The following is a description of a gene set: Orthostatic hypotension due to autonomic dysfunction studied in species Homo sapiens Human Gene Set: HP_ORTHOSTATIC_HYPOTENSION_DUE_TO_AUTONOMIC_DYSFUNCTION, and this is the list of marker genes: LRRK2, TTR, ARSA, GIGYF2, COQ2, VPS35, GSN, SNCA, LEP, GBA1, NTRK1, DNAJC13, LEPR, EIF4G1, PSAP